The following is a description of a gene set: Mouse Gene Set: GOBP_REGULATION_OF_STEM_CELL_POPULATION_MAINTENANCE species: Mus musculus Any process that modulates the frequency, rate or extent of stem cell population maintenance., and this is the list of marker genes: Arid4b, Wdr43, Tcl1, Pax2, Sinhcaf, Actb, Brd9, Zfp322a, Ogt, Smarcd1, Rest, Tead1, Trp63, Zc3h13, Sap30, Pax8, Ncoa3, Loxl2, Arid1a, Cnot1, Dpf2, Hdac1, Zfp706, Rbbp7, Hmga2, Bicra, Taf5l (TATA-box binding protein associated factor 5 like), Smarca2, Bcl7b, Tal1, Dsg2, Phf10, Smarca4, Kdm3a, Smarce1, Brms1l, Suds3 (NCBI Gene Id 71954), Ing1, Sirt6, Hnf1b, Bcl7c, Hdac2, Kdm2b, Myc, Wnt9b, Cnot3 (NCBI Gene Id 320303), Sin3a, Mir294, Bicral, Esrrb, Smo, Taf6l, Sav1, Ing2, Yap1, Elavl1, Brms1, Prdm14, Lbh, Kat2a (K(lysine) acetyltransferase 2A), Tead4, Sap30l, Rbbp4, Smarcb1, Actl6b (actin-like 6B), Tet1, Bmp7, Sap130, Actl6a, Bcl7a, Ptn, Tcf7l1, Ss18, Tead3, Cnot2, Smarcc1, Arid4a